Given this list of marker genes Supt16, Ccar2, Hnrnpu, Epop, Supt5, Wdr43, Nelfb, Ctnnb1, Wdr82, Setd2, Med31, Map2k1, Pcid2, Ncbp2, Sox10, Axin1, Med8, Cdk13 (NCBI Gene Id 69562), Nelfe, Chaserr, Zmynd8, Ell3, Hand2os1, Polr1f, Med21, Shh, Supt6, Tex24, Ldb1, Gtf2f1, Rnf168, Med19, Iws1, Med6, Ell2, Paf1, Ell (NCBI Gene Id 234380), Supt4a, Med22, Elof1, Supt4b, Med23, Setd5, Usp7, Glyr1, Med4, Pbrm1, Med24, Ercc3, Elp2, Nelfcd, Ccnk, Rnf8, Eapp, Ncbp1, Pwwp2b, Med28, Ccnt2, Zc3h4, Hexim1, Polr1e, Cdk9, Dab2, Gtf2f2, Med26, Skic8, Med10, Elob (elongin B), Med20, Ercc6, Tcea3, Kat7, Ccnt1, Med11, Sirt6, Med30, Zfp326, Med7, Btbd18, Pwwp2a, Zmynd11, Ubtf, Eaf2, Brd4, Tcea2, Med9, Cbx7, Eny2 (ENY2 transcription and export complex 2 subunit), Ikzf1, Eloa, Polr2m, Med15, Polr1d, Rtf1, Tcea1, Adrm1b, Med14, Polr2i, Gtf2h5, Ezh2, Nelfa, Eaf1, Cdc73, Med25, Med16, Ercc2, Med17, Med29, Sart3, Ctr9, Tefm, Med27, Leo1, Usp15, Scaf8, Recql5, Med1, Polr2e, Cdk12, Med18, Adrm1, Parp1, here is a description of the gene set: species: Mus musculus Mouse Gene Set: GOBP_DNA_TEMPLATED_TRANSCRIPTION_ELONGATION The extension of an RNA molecule after transcription initiation and promoter clearance at a DNA-dependent RNA polymerase promoter by the addition of ribonucleotides catalyzed by an RNA polymerase.